The following is a description of a gene set: Type II interferon to Jak-STAT signaling pathway. Pathway ID: N01559. Pathway type: Reference. Pathway class: nt06518 JAK-STAT signaling. Pathway Definition from KEGG: IFNG -> (IFNGR1,IFNGR2) -> (JAK1+JAK2) -> (STAT1,STAT3) => (IL27,IFNA,IFNG) species: Homo sapiens Human Gene Set: KEGG_MEDICUS_REFERENCE_TYPE_II_INTERFERON_TO_JAK_STAT_SIGNALING_PATHWAY, and this is the list of marker genes: IFNA13, IFNA5, IFNGR2, IFNA16, JAK1, IFNA1, IFNA7, STAT3, JAK2, IFNA8, IFNA10, IFNA14, IL27, STAT1, IFNA21, IFNA17, IFNG, IFNA6, IFNA2, IFNGR1, IFNA4